Given this list of marker genes FLT3, here is a description of the gene set: studied in species Homo sapiens Reactome Pathway: Drug resistance of FLT3 mutants part of: FLT3 signaling in disease FLT3 is mutated in ~30% of acute myeloid leukemias (AML), with internal tandem duplications (ITDs) representing the majority of these mutations and activating point mutants occurring at lower frequency. FLT3 mutations also occur at lower rates in other cancers. Mutation of FLT3 has been identified as a driver in progression of AML and in consequence is a promising therapeutic target. A number of first and second generation inhibitors have been demonstrated to have activity against FLT3, but accumulation of secondary mutations leads to the development of resistance. These secondary mutations further shift the equilibrium of the receptor toward the activated state, making even the second-generation type II TKIs less effective. In consequence, considerable effort is devoted to discovery of type II and, in particular, type I TKIs that are active against highly activated FLT3 alleles.